Given this list of marker genes Epo, Pik3r5, Pik3cb, Epor, Irs2, Gab1, here is a description of the gene set: This event has been computationally inferred from an event that has been demonstrated in another species.<p>The inference is based on the homology mapping from PANTHER. Briefly, reactions for which all involved PhysicalEntities (in input, output and catalyst) have a mapped orthologue/paralogue (for complexes at least 75% of components must have a mapping) are inferred to the other species. studied in species Mus musculus part of: Signaling by Erythropoietin Reactome Pathway: Erythropoietin activates Phosphoinositide-3-kinase (PI3K) electronically inferred by orthology from the curated human pathway